Given this list of marker genes Gm2a, Psap, Neu4, Prkcd, Gba1, Neu3, Acer1, Glb1, Lct, Gla, Acer3, Asah1, Asah2, Neu2, Hexb, Acer2 (alkaline ceramidase 2), Cel, Neu1 (NCBI Gene Id 18010), Galc, Hexa, Gba2, here is a description of the gene set: Mouse Gene Set: GOBP_CERAMIDE_CATABOLIC_PROCESS species: Mus musculus The chemical reactions and pathways resulting in the breakdown of ceramides, any N-acetylated sphingoid.